The following is a description of a gene set: Neighborhood of ESPL1 extra spindle poles like 1 (S. cerevisiae) in the GNF2 expression compendium species: Homo sapiens Human Gene Set: GNF2_ESPL1 Neighborhood of ESPL1, and this is the list of marker genes: AURKB, PCNA, MAD2L1, CDCA8, TPX2, ASPM, SMC2, KIF20A, PLK1, NCAPD2, CKS1B, MELK, MKI67, ESPL1, CDC20, CENPA, UBE2C, PAICS, CENPM, MCM4, ASF1B, CCNA2, CCNB2 (NCBI Gene Id 9133), RRM2, BIRC5, KIF11, TOP2A, BUB1, HMMR, SPAG5, BUB1B, MCM6, CENPE, KIF2C, FOXM1